The following is a description of a gene set: Human Gene Set: EGR_Q6 species: Homo sapiens Genes having at least one occurrence of the motif GTGGGSGCRRS in the regions spanning 4 kb centered on their transcription starting sites. This matches the EGR1, EGR2, EGR3 transcription factor binding site V$EGR_Q6 (v7.4 TRANSFAC)., and this is the list of marker genes: EML5, RNF10, RAB26, MORF4L2, JADE2, SH3KBP1, DLGAP4, TLCD4, PITPNA, VAX1, SLC39A3, GBX2, NLK, ADAMTS3, ZFP36L1, BCL2L11, BRD2, OSBP2, RGL1, SP1, GAD1, CALR, CRTC2, ZNF414, ANP32E, DNAJB5, PPP3CB, CHRDL1, KCNN2, PTMS, CACNA1A, VWA3B, HHEX, DENND2C, RRP8, FBXO36, NFYC, HEXIM2, CBX4, PDGFB, CGB7, PIAS3, MMP1, INSM1, NETO1, FSTL5, HOXB8, RAD23A, PSD, VKORC1L1, PDE10A, CDK2AP1, TRAF4, PCDH17, MARCHF10, TGIF2, LYPLA2, LMO3, SLITRK5, NAT8L, MTA2, ARL1, RNF44, GRB2, MAP1A, CAND1, PRPF3 (NCBI Gene Id 9129), SMARCA5, LHB, UBE3A, TGIF1, PPRC1, KDM6A, MGLL, SERTAD1 (SERTA domain containing 1), PCSK2, GPHN, HMGA1, ZHX2, IRF2BPL, KCNAB3, AR, KIFC2, QRICH1, ORC4, EFEMP2, EFNB3, KCNH3, CCDC102A, SLC9A3 (NCBI Gene Id 6550), SYT6, CTCF, ZFTRAF1, TNFRSF12A (NCBI Gene Id 51330), VAMP2, ZMYM2, PTMA, TFAP2C, CXXC5, CORO1C, CACNA1B, HYAL2, TXNDC12, APLP2, OLIG1, VLDLR, NAA35, UBTF, IL21, HIC1, HK2, BRWD3, GABRG2, TRIR, CELF4, PPP1R16B, AGO1, FCHSD1, RNF24, KPNB1, CNNM4, CGB8, SEC63, GPR162 (G protein-coupled receptor 162), CRYAB (NCBI Gene Id 1410), MATR3, HSPA4, COL27A1, NR5A1, CGB5, TGFB1I1, TNIP2, ANKRD13A, C2CD2L, AP3S1, NUMBL, ERF, SLC9A5, ITGB8, RHOG, YWHAG, NUAK1, KCNJ10, BMP4, NKX2-2, UST, NR2F2, RASAL2, TUG1, CGB3, TPGS2, KLF13, SLC22A17, HSPB2, CACNA1D, KRCC1, ACE, CDC73, HCN4, SPEG, ADSS2, ABHD1, FCHSD2, PPARGC1B, AK5, SRCIN1, SIK2, ING2, TSC2, PPM1D, PHF12, CDX1, ICAM5, TENT5C, ADCY8, HCFC1R1, UBE2M, CLPTM1, TOX2, NEFL, PRDM10, IGF2BP1, THOC6, NACC1, FBRS, NPAS4, SIX4, CLIP2, DET1 (DET1 partner of COP1 E3 ubiquitin ligase), PDZD8, NEUROD2, HNRNPL, PRX, ZFP36, KCNB1, CYLD, IL13RA1, MID1IP1, PPP3CA, RASGEF1A, WDR81, ERGIC3, DDX6, ATG12, PTCH1, KCNQ5, ABI2, CELSR3, INA, YTHDF2, NTN3, MNT, PTCHD1, EIPR1, TPM4, CALU, SP4, ARPC5, MACROD2, HID1, IRX2-DT, ISG20L2, UNC5C, NRK, NSD3, WDR44, CBLN1, ZNF575, DLX3, MSI1, STARD13, HOXA3, PRPF6, REPS2, NRDC, DIAPH1, EGR1, OSTC, KLF10, STXBP2, ACER3, NTHL1, CAMKV, DLL4, IRX2, ILK, PLD5, EGR2, XIRP1, METTL25B, FEV (NCBI Gene Id 54738), SAMD10, MAP3K7, MIR17HG, UNC119, MIR22HG, SLC25A12, ZNF703, PPP1R9B, TRAPPC12, HAS3, PARP6, EED, POLR3E (RNA polymerase III subunit E), C1orf21, RAPGEFL1, AKIRIN2, PACS1, KCNH5, EYA4, RELB, LMAN1, ABCB6, USP15, PGRMC2, SELENOF, ASB1, CDH2, SIPA1, NCS1, SPTB